The following is a description of a gene set: from publication Rashi-Elkeles S, Elkon R, Weizman N, Linhart C, Amariglio N, Sternberg G, Rechavi G, Barzilai A, Shamir R, Shiloh Y (PMID 16314843) species: Mus musculus Cluster 1: ATM dependent genes induced at 30 min after ionizing radiation treatment. The ATM protein kinase, functionally missing in patients with the human genetic disorder ataxia-telangiectasia, is a master regulator of the cellular network induced by DNA double-strand breaks. The ATM gene is also frequently mutated in sporadic cancers of lymphoid origin. Here, we applied a functional genomics approach that combined gene expression profiling and computational promoter analysis to obtain global dissection of the transcriptional response to ionizing radiation in murine lymphoid tissue. Cluster analysis revealed a prominent pattern characterizing dozens of genes whose response to irradiation was Atm-dependent. Computational analysis identified significant enrichment of the binding site signatures of NF-kappaB and p53 among promoters of these genes, pointing to the major role of these two transcription factors in mediating the Atm-dependent transcriptional response in the irradiated lymphoid tissue. Examination of the response showed that pro- and antiapoptotic signals were simultaneously induced, with the proapoptotic pathway mediated by p53 targets, and the prosurvival pathway by NF-kappaB targets. These findings further elucidate the molecular network induced by IR, point to novel putative NF-kappaB targets, and suggest a mechanistic model for cellular balancing between pro- and antiapoptotic signals induced by IR in lymphoid tissues, which has implications for cancer management. The emerging model suggests that restoring the p53-mediated apoptotic arm while blocking the NF-kappaB-mediated prosurvival arm could effectively increase the radiosensitivity of lymphoid tumors. Human Gene Set: RASHI_RESPONSE_TO_IONIZING_RADIATION_1, and this is the list of marker genes: CCDC186, CDK4, SLC23A3, HSD11B1, IER3, UTF1, FOXQ1, ADRB2, G0S2, SGK1, WNT4, CCT3, EGR1, GSDME, GADD45A, S100A1, JUN, FOS, IER2, LIN9, SLBP, VEGFA, H2AC21, TIMM8A, CWC15, COL15A1, ZAP70, ATF3, SLC2A1, WDR74 (WD repeat domain 74), DUSP1, PAFAH1B2, PLXNA2, SEC23A, HNRNPLL, WWP2, DNAJC17, SERPINB6, ZFP36